Given this list of marker genes Lmna, Zeb1, Lrp5 (low density lipoprotein receptor-related protein 5), Fbxw4, Prrx1, Fgf4, Irs1, Six1, Gas1, Lrp6, Hmgb1, Kdr, Smo, Dchs1, Sox9, Bmp4 (NCBI Gene Id 12159), Wnt2, Tbx18, Ctnnb1, Pdgfa, Shh, Prrx2, Arhgap5, Osr1, Hand2, Fgf7, Foxf1, Fgfr2, Dchs2, Bmp7, Mycn, Prkar1a, Ihh, Isl1, Fat4, Nfib, Stat1, Wnt11, Bmpr1a, Msx1, Tbx2, Myc, Ctnnbip1, Shox2, Wnt5a, Six2, Fgf9, Ptn, Phf14, Fgfr1, Tbx1, Tgfbr2, Gpc3, Irs2, Bmp2, Foxp2, Chrd, Foxp1, here is a description of the gene set: Mouse Gene Set: GOBP_MESENCHYMAL_CELL_PROLIFERATION studied in species Mus musculus The multiplication or reproduction of cells, resulting in the expansion of a mesenchymal cell population. A mesenchymal cell is a cell that normally gives rise to other cells that are organized as three-dimensional masses, rather than sheets.